The following is a description of a gene set: Mouse Gene Set: GOCC_AZUROPHIL_GRANULE species: Mus musculus Primary lysosomal granule readily stainable with a Romanowsky stain., and this is the list of marker genes: Vamp8, Stx7, Defa32, Prtn3 (NCBI Gene Id 19152), Prss57, Defa20, Anxa11, Defa42, Hexb, Hexa, Defa43, Nos1, Snap23, Mpo, Stxbp2, AY761185, Defa39, Stx3, Defa38